Given this list of marker genes HSP90AB1, COMMD1 (copper metabolism domain containing 1), MIR520E, GOPC, RIC3, KCNAB2, ASTN2, PICALM, TOR1A, FCER1G, LRIG2, TM9SF4, ACTN2, ERBB4, TAX1BP3, ABCA2, MAP1A, STX3, STX4, TNF, EPHB2, NEDD4L, GBF1, BDNF, EGF, ARF6, RAB11FIP5, CD247, AKT1, RAB11B, TYROBP, MIR520B, TMEM35A, SNX33, GPD1L (NCBI Gene Id 23171), ABCA12, ABCA7, RANGRF, CAV3, CTNNB1, LEPROT, GPM6B, HFE, here is a description of the gene set: studied in species Homo sapiens Human Gene Set: GOBP_REGULATION_OF_PROTEIN_LOCALIZATION_TO_CELL_SURFACE Any process that modulates the frequency, rate or extent of protein localization to the cell surface.